Given this list of marker genes Gtf3c6, Mfsd4b1, Gm24889, 4930547M16Rik, 5930403N24Rik (NCBI Gene Id 320504), Col10a1, 4930543K20Rik, Mettl24, Fyn, Gm32338, Marcks, Hs3st5, Ddo, Gm18986, Cdc40, Ak9, Gm18346, Slc16a10 (solute carrier family 16 (monocarboxylic acid transporters), member 10), Calhm5, Cdk19os, Gm8055, Rwdd1, Tspyl1, A830082N09Rik, Gm18252, Gm16364, Gm48057, Gm32284, Ccn6, Cdk19, Amd2, Tube1, Gm6963, Gm8948, Sult3a1, Clvs2, Traf3ip2, Gm31562, Rev3l, Frk, Gm17795, Amd1, Gm7940, Gm19611, Hdac2, Idi1-ps3 (isopentenyl-diphosphate delta isomerase, pseudogene 3), Tspyl4, Fig4, Gm15939, Trappc3l, Gm22554, Wasf1, Calhm4, Rfpl4b, Gm26535, D030034A15Rik (RIKEN cDNA D030034A15 gene), Gm16210, Gm6477, Fam229b, Sult3a2, Lama4, Slc22a16, Dse, Mfsd4b3-ps, 1700054O05Rik, Gm18305, Nt5dc1, Gm26341, Mfsd4b4, Gm31378, Rsph4a, Gm8834, Zup1, Gm10327, Gpr6, Snord3a, Gm25613, Gm48018, Gm47512, Gm22105, Gm31992, Mfsd4b5, Gm18671, Gm17779, Gm40623, Gm31848, Calhm6, 4930591E09Rik, Mfsd4b2, Gm8899, E130307A14Rik, Gm18729, Rpf2, A930033M14Rik, here is a description of the gene set: Mouse Gene Set: chr10B1 species: Mus musculus